Given this list of marker genes Pdgfb, Osr1, Shh, Egr1, C3ar1, Pdgfd, Gata3, Stat1, Serpinb7, Lin28a, Itgb3, Pdgfa, Ifng, Flcn, Pdgfrb, Gpc3, Bmp4, Myc, Bmp7, Il6ra, Bmp2, Cflar, Wt1, Ptch1, here is a description of the gene set: Mouse Gene Set: GOBP_CELL_PROLIFERATION_INVOLVED_IN_KIDNEY_DEVELOPMENT species: Mus musculus The multiplication or reproduction of cells, resulting in the expansion of the population in the kidney.